The following is a description of a gene set: Human Gene Set: TCATCTC_MIR143 Genes having at least one occurence of the motif TCATCTC in their 3' untranslated region. The motif represents putative target (that is, seed match) of human mature miRNA hsa-miR-143 (v7.1 miRBase). studied in species Homo sapiens, and this is the list of marker genes: MAPK7, SMARCD2 (NCBI Gene Id 6603), HABP2, ATP6V1A, LARP4, CREB5, TRAPPC8, ADD3, NETO1 (NCBI Gene Id 81832), SH3PXD2A (NCBI Gene Id 9644), CLTRN, ELMOD1, ARL15, AGPAT1, MAP3K7, ATP10A, LARP1, NECAP1, TAOK2, PHTF2, PRKCE, PPEF2, GIGYF2, CREBZF, HOXA7, RNF6, PHF20L1, BOLA2, SSH2, BICD1, CSNK1G3, FAM117A, NUP35, MIPOL1, ITM2B, CRELD1, SEPTIN4, TSC22D3, SCAMP1, PHF6, ZDHHC9, GALNT7, PNCK, REEP3, NUAK2, BRD2, ENSA, SLC16A2, SRSF11, HMBS, SYT3 (NCBI Gene Id 84258, synaptotagmin 3), DIP2B, DTNA, NEXMIF, ITGA6, PTBP3, ESRRG, MYO6, QKI, AKAP13, PSD3, ZFP82, TMEM121, MLLT3, AKAP6, GLI3, PC, PPM1E, SOBP, GID8, ESYT3, AKIP1, LRP12, DTNB, PTPN4, RALBP1, AHCYL1, RAB7A, LMO4, PRPF19, ZNF607 (zinc finger protein 607), ASB6, MARCHF3, SIGMAR1, GNS, STRN3, ST8SIA4, MAP1B, AMMECR1, BCORL1, GABARAPL1, HIPK1, CNNM3, BRCA1, RMND5A, VAPB, ITPR1, SCAMP4, MOGS, CNTD1, LASP1, PSME4, KRAS, SIDT1, FGF1, ARK2C, SCAF8, CADM2, ETV6, CBFB, GRHL2, HOXA5 (NCBI Gene Id 55953), TPM3, CNOT4, EGLN1, COL5A2, TUBGCP6, ERBB3, SIX4 (NCBI Gene Id 51804), RBM24, BSN, ZBTB44, NEURL1, KCNH8, MSI2, SMNDC1, MCF2, IGFBP5, UNC5A, HTR2C, MAB21L1, OTUD4, SEPTIN3, MAF, CTNND1, KLC2, MEX3C, ABCB9, FAM221B, FNDC3B, UBE2E3, SLC38A2, RSRC2, TARDBP, NAA30 (N-alpha-acetyltransferase 30, NatC catalytic subunit), NTRK2, GFPT2, DNMT3A